The following is a description of a gene set: A G protein-coupled receptor signaling pathway initiated by an extracellular purine nucleotide binding to its receptor, and ending with the regulation of a downstream cellular process. Human Gene Set: GOBP_G_PROTEIN_COUPLED_PURINERGIC_NUCLEOTIDE_RECEPTOR_SIGNALING_PATHWAY studied in species Homo sapiens, and this is the list of marker genes: P2RY1, P2RY11, P2RY2, GPR87, P2RY14, GPR34, PTAFR, ADORA1, P2RY12, GPR171, P2RY8, P2RY4, P2RY6, P2RY13